The following is a description of a gene set: Any process that modulates the rate frequency or extent of gastric secretion. Gastric secretion is the regulated release of gastric acid (hydrochloric acid) by parietal or oxyntic cells during digestion. Mouse Gene Set: GOBP_REGULATION_OF_GASTRIC_ACID_SECRETION species: Mus musculus, and this is the list of marker genes: Kcnq1, Sct, Nmu, Ptger3, Tff2, Hip1r, Gpr39